Given this list of marker genes NSMF, NTRK2, CDO1, MIR421, MMP2, MTOR, COL1A2, ZEB1, MAT2A, XBP1, COL4A1, LRP11, GHSR, PCNA, PDGFC, GRIN2D, SESN2, HNRNPAB (heterogeneous nuclear ribonucleoprotein A/B), LCN2, GLRA1, HNRNPD, COL3A1, DNMT1, BCL11A, CYBB, PDX1, GRIA1, LAMTOR3, ATP2B4, KCNB1, MTHFR, MIR455, GRIN1, ABCB1, CAPN2, F7, CPS1, UMOD, COL4A6 (collagen type IV alpha 6 chain), SH3BP4, NEURL1 (neuralized E3 ubiquitin protein ligase 1), PDGFRA, CPEB1, IPO5, TUBA1A, LARS1, CYBA, RRAGB, VEGFA, LYN, RPTOR, BCL2L1, PLEC, FYN, CREB1, CPEB4, PIK3CA, RELA, GLRA2, CHUK, BAIAP2, MIR545, LAMTOR2, PNPLA3, SAMTOR, SIPA1, MIR342, RRAGA, PPP1R9B, AMIGO1, NFE2L2, CUL3, TNF, MIR762, PRKN, RRAGD, EDN1, SOCS1, CASP3 (NCBI Gene Id 836), EGFR, CASTOR1, GCLM, MYD88, HPCA, TMBIM6, CPEB3, NTRK1, SLC1A2, COL6A1, STAMBPL1, COL16A1, GDF10, UBR1, PKD2L1, PDGFD, SLC38A9, COL18A1 (NCBI Gene Id 80781), CASTOR2, LAMTOR5, CFL1, RRAGC, FUT1, EP300, GPRC6A, GSTP1, LAMTOR1, CEBPB, MIR224, GCLC, MIR95, COL1A1, TOMM70, AQP2, EIF2S1, HMGCS2, HSF1, ALAD, HCN1, UFL1, SPAAR, SIX1, AIFM1, SLC7A5, SST, MIR92A1, SESN1, MEAK7, RBX1, CASTOR3P, KLHL22, LAMTOR4, PRMT1, PKD2, COL5A2, DNMT3A, MMP3, AVPR1A, UBR2, KLF2, PIK3C3, ASS1, SESN3, here is a description of the gene set: Human Gene Set: GOBP_RESPONSE_TO_ACID_CHEMICAL species: Homo sapiens Any process that results in a change in state or activity of a cell or an organism (in terms of movement, secretion, enzyme production, gene expression, etc.) as a result of a stimulus by the chemical structure of the anion portion of a dissociated acid (rather than the acid acting as a proton donor). The acid chemical may be in gaseous, liquid or solid form.